Given this list of marker genes CHCHD10, ANKRD1, AGRN, UNC13A, DES, CHRND, VCP, GATA4, TBK1, DSG2, MYOZ2, ERBB4, TBX20, LRP4, PON3, ACTN2 (NCBI Gene Id 88), FIG4, PSEN1, NEK1, ACTC1, DCTN1, TXNRD2, LDB3, DSP, LMOD2, VEZF1, ABCC9, NEFH, CRYAB, TMPO, RBM20, CHRNA1, TAF15, PRPH, ANG, FUS, GATAD1, PLN, DOLK, RAPSN, TNNI3, FLNC, JPH2, BAG3, LMNA, VCL, TAF1A, SCN4A, OPTN, DAO, TCAP, TTN, COL13A1, FKTN, FHL2, MYH7, PON1, CAP2, RAF1, BAG5, NEXN, UBQLN2, KIF20A, DMD, MATR3, PFN1, TNNC1, SOD1 (superoxide dismutase 1), TPM1, SGCD, SDHA, MYH6, CFAP410, CITED2, PRDM16, PSEN2, GET3, GLT8D1, DOK7, LAMA4, CHRNE, SQSTM1, TAFAZZIN, TLL1, MUSK, ATXN2, TNNT2, HAND2, GLE1 (NCBI Gene Id 8012), CCNF, GATA6, CHRNB1, PPCS, ANXA11 (NCBI Gene Id 311), TREM2, AK9, MYBPC3, VAPB, PPARGC1A, HNRNPA1, CHMP2B, RPL3L, CSRP3, NKX2-5, TARDBP (TAR DNA binding protein), SCN5A, MYPN, PON2, here is a description of the gene set: Orthopnea species: Homo sapiens Human Gene Set: HP_ORTHOPNEA A sensation of breathlessness in the recumbent position, relieved by sitting or standing.